Given this list of marker genes OR1N2, EPB42, OR6C70, PIK3CG, ABCA9, TREM1, GIMAP7, CSMD3, OR5V1, GPR15, CLCA1 (chloride channel accessory 1), WNT8B, OVCH2, VWA2, BLNK, TNIP3, PRG2, FPR2, TRIM36, TMCO5A, CLEC1B, ZIC4, TFEC, KRTAP13-2, ALB, OTC, TMPRSS11A, SEMG2, OR11G2, ALDH8A1, UBD, ANXA13, KRTAP13-1, SLN, ZIC1, KCNA10, TECTA, ATOH1, TMTC1, ASTN1, IGFL3, TAC1, ELMOD1, KLRF1, TPH1, PGR, KRT222 (NCBI Gene Id 125113), VAX1, SIGLEC6, ENPP5, ERG, DEFB126, NR1H4, MARCO, OR10A7, GPM6B, RNASE6, STOML3, FGF9, DLGAP1, MOBP (myelin associated oligodendrocyte basic protein), PWWP3B, CD40LG, SLC17A6, GFRAL, SLC8A3, IL9, SAA4, AQP4, ASB15, OR6C6, OR8D1, F11, GPR88, OR10P1, OR2AT4, CDH20, OR9Q2, PTH, PCK1, ARPP21, FGF23, SDR9C7, EN2, ENPP2, AFP, SPRR2G, USP26, CTLA4, POSTN, ATOH7, ZPBP2, ARMCX4, MEIOB, GRM3, OR8A1, IAPP, OR6X1, NR5A2, SLC26A9, SLC26A3, GAP43, ATP1B4, SIAH3, GPHB5, CLECL1P, A1CF, CD86, AMER2, RNF220, NLRP14, GAS2, ABCA6 (ATP binding cassette subfamily A member 6), EYA1, OR1D2, GJB6, CRNKL1, C1QTNF7, OR52I2, NLRP9, CLDND1, CCDC198 (coiled-coil domain containing 198), OR6C74 (olfactory receptor family 6 subfamily C member 74), SIGLEC7, PHACTR1, IFNG, OR2G3, FAM216B, GZMH, DYNAP, IKZF3, HABP2, OR52B4 (olfactory receptor family 52 subfamily B member 4), GABRA1, ICA1 (islet cell autoantigen 1), POU2AF2, NPVF, ENTPD1, GYS2, IL16, CXCR4, OR4D10, CCDC60, C4BPA, CHRM2, OR4D11, ABCB5, NTS, TAS2R1, G6PC2, SULF1, RNASE9, LONRF2, MBD3L1, JAML, TMPRSS15 (NCBI Gene Id 5651), SMR3B, IGF2BP1, SPIC, NRG4, BRINP2, OTOR, OR2AG1, ASCL4, LALBA, CHAT, OR5K4, SLC22A25, ATL1, DRD3, ELMO1, OR9A2, LAMB4, RUNX1T1, COL14A1, LILRB5, CD1D, TAT, ITK, TFAP2D, MC2R, OR52K1, HLA-DQA2, ACADL, KIRREL3, CCDC181, LEMD1, CD1A, HOXB9, LIN28B, ASAH2, RNASE12, C11orf40, SLC30A8, here is a description of the gene set: species: Homo sapiens Epigenetic silencing in cancer cells is mediated by at least two distinct histone modifications, polycomb-based histone H3 lysine 27 trimethylation (H3K27triM) and H3K9 dimethylation. The relationship between DNA hypermethylation and these histone modifications is not completely understood. Using chromatin immunoprecipitation microarrays (ChIP-chip) in prostate cancer cells compared to normal prostate, we found that up to 5% of promoters (16% CpG islands and 84% non-CpG islands) were enriched with H3K27triM. These genes were silenced specifically in prostate cancer, and those CpG islands affected showed low levels of DNA methylation. Downregulation of the EZH2 histone methyltransferase restored expression of the H3K27triM target genes alone or in synergy with histone deacetylase inhibition, without affecting promoter DNA methylation, and with no effect on the expression of genes silenced by DNA hypermethylation. These data establish EZH2-mediated H3K27triM as a mechanism of tumor-suppressor gene silencing in cancer that is potentially independent of promoter DNA methylation. from publication Kondo Y, Shen L, Cheng AS, Ahmed S, Boumber Y, Charo C, Yamochi T, Urano T, Furukawa K, Kwabi-Addo B, Gold DL, Sekido Y, Huang TH, Issa JP (PMID 18488029) Human Gene Set: KONDO_PROSTATE_CANCER_WITH_H3K27ME3 Top genes with high histone H3 trimethylation mark at K27 (H3K27me3) in PC3 cells (prostate cancer), by ChIP-chip assay on an 88K microarray (all promoters).